The following is a description of a gene set: Type I Interferons encompasses a large family of closely related cytokines comprising of at least 13 IFN-α isotypes and single IFN-β. Both IFN-α and IFN-β exert their activity through a common receptor IFNAR. Type I Interferons have broad regulatory effects and various subtypes of dendritic cells are influenced by this cytokines. In our study we asked question whether the low, constitutive levels of type I Interferons produced under steady state conditions are important for proper function of splenic conventional dendritic cells. from publication Zietara N, Łyszkiewicz M, Gekara N, Puchałka J, Dos Santos VA, Hunt CR, Pandita TK, Lienenklaus S, Weiss S (PMID 19581626) species: Homo sapiens Genes up-regulated in splenic dendritic cells from IFNB1 knockout mice: CD8A+ versus CD8A- populations. Human Gene Set: GSE12392_CD8A_POS_VS_NEG_SPLEEN_IFNB_KO_DC_UP, and this is the list of marker genes: PON3, CTSV, PRPSAP1, ELP2, NDE1, LGALS3BP, PSMA1, HHEX, DYNLRB1, MMP12, NCOA4, RERE, ARG1, MKLN1, DERL2, LAT2, YIPF5, MSL1, RANBP9, BOLA2, CYB5A, DNASE1, LY6D, MOCS2, DDT, PROCR, PLPP3, KDM3B, ZZZ3, TBCEL, HLA-C, RARS2, ANAPC2, RTRAF, FOXRED1, C5orf15, SGK1, CAMLG, SPART, SIAE, RNPS1, PJA1, EIF3M, CSTB, GNG4 (NCBI Gene Id 2786), PTCD2, URI1, NAA40, DNMT1, PGAM1, CORO1B (coronin 1B), EIF3C, TAPBP, ADAM2, LGALS1, M6PR, MRPL13, SCPEP1, TNFRSF21, LPL, DNAJC2, CAPG, DRAM2, IRF1, ARFGEF1, TBC1D23 (NCBI Gene Id 55773), ATG5, GCLM, MEN1, AHCYL1, TUBGCP4, NCOA6, PTGR1, CTSB, RPRD1B, LIMA1, RNASET2, RFK, NDUFS3, NDUFB3, NR2C1, ACOX1, ZBTB7B (zinc finger and BTB domain containing 7B), VPS26B, LSG1, TOMM7, PKD2, ING4, CREBRF, GALNT2, NPC2, MAP4K3, DCAF12, CMTR2, FBXO6, NUP88 (nucleoporin 88), EVL, MITF, GLG1, EIF3A, PFN2, SIRPA, CNOT2, TCEA1, GSTA3, USP18 (NCBI Gene Id 11274), CPEB2, HMGCL, TPI1, SWAP70, PISD, ENO1, MRPS26, TRAPPC1, RIN2, PFKL, BABAM2, LIPE, MRPL4, CREG1, LRRC8C, XPA, STAT1, OSBPL11, SOCS2, VPS26C, PSMD1, MOV10, HMOX1, MYH8, POLR2G (NCBI Gene Id 5436), RP9, TAP1 (NCBI Gene Id 92050), PI4KA, CACNB3, STAB1, VTA1, COA6, SH2B1, ANXA4, TACR2, CHCHD7, PDE6D, MTHFD2, ATXN2, MRPL27, EHMT2, SACM1L, CTBP2, DNMT3A, LY9, ESD, GBA1, LSM1, PARK7, NUDT1, MMP10 (NCBI Gene Id 4319), CYBB, MAD2L1BP, DDX52, IL12A, SPSB1, PCYOX1, MAK16, DDAH2, PSMB5, NMT1, TMEM230, PPP3CC, PSME1, AP3D1, GPC1, TRAF6, TOR3A, CPNE6, UCHL1, PRDX1, PRKDC, CHMP5, TCF12, NIT1, AKR1B15, TBCA, LXN, CD300C, RHOQ, NOS2 (nitric oxide synthase 2), PAM16, VPS41, EIF2AK2, MAT2B, KIF3C, MYO5A, NIT2, PRDX6, ECHS1, PLD1, PKM, UTP3, FAM89B